The following is a description of a gene set: Human Gene Set: MIR10394_5P studied in species Homo sapiens Genes predicted to be targets of miRBase v22 microRNA hsa-miR-10394-5p in miRDB v6.0 with MirTarget v4 prediction scores > 80 (high confidence targets). from publication Chen Y, Wang X (PMID 31504780), and this is the list of marker genes: NTNG1, DNAJC6, PTCHD1, PNPLA5 (patatin like phospholipase domain containing 5), NFATC2, ADAM7, SPAST, WNK3, ADAM12, PSME4, DIRAS1, SUFU, FHL1, CDS2, TMEM62, N4BP1, USB1, ANKRD17, STAU1, PPARD, GPHN (NCBI Gene Id 57566), KCTD9, TPBG, HACD2, CNTD1, ASB7, GUCA1ANB-GUCA1A, XYLB, TOR2A, ATXN1L, SH3PXD2A, FAM168B, RGMA, TUB, SLC35F6, RBM46, UBE2W, RASGEF1B, USP9X, NPC1L1, SYK, CDCA2, ERLIN1, EBPL, JAM2 (junctional adhesion molecule 2), WSB1 (NCBI Gene Id 26118), ENGASE, ZC2HC1C, SRGAP3, DNAJB1, MTCL2, ORAI2, KIAA0513, ADAR, BICDL1, IPCEF1, CTNND1, CEMIP, CCND2, AP2A2, HCFC1R1, GRIK3, POLDIP2, PPP4R3A, ITPR2, ALDH7A1, PDE3B, SPRY3, AGO1 (NCBI Gene Id 26523), EGLN3, LDAH, DICER1, SETD3, DNAAF9, IGDCC3, CASTOR2, POLR2J3, LACC1, NCKIPSD, UHRF1, PELI2, ST3GAL5, GRM1, CNTFR (NCBI Gene Id 1271), CNOT2, TSPAN13, CACNA1A, QSOX2, FIBIN, RRP7A, PLAGL2, PPIF, FOXI1, MYT1L, EPHA3, USP20, POM121, ICE1, MLXIP, NMNAT2, LHFPL5, ATXN1, ASTN1, FAM120A, TDRKH, KAT7, GSTM4, C1orf21, LBH, TM9SF3, SSH1, ANKS1A, ARF6, SLC24A4, GLI3 (GLI family zinc finger 3), FBXL8, EIF5A, NCS1, ABI2, BCL2L11, ZDHHC6, SNTG2, CHMP7, CUL4A (NCBI Gene Id 8451), PDE2A, GLIS3, KLK6, ST6GAL2, TMEM230, ZNF592, PCBP4, ARHGAP17, CCR4, DOCK3, MAP1B, AMMECR1, RGS16 (regulator of G protein signaling 16), PTPN11, PRRC2B, ACIN1, C1orf226, DNALI1, SMARCE1 (NCBI Gene Id 6605), TTYH2 (NCBI Gene Id 94015), SLC30A4, SBNO1, LSM14A, JCAD, FAM98A, SNX21, GUCA2A, ADNP2, DSE, NATD1, CLTCL1, COPS2, MKNK1, CABYR, EIF5A2, PPP1R3B, FAM217B, SLC4A4, MUC6, RAPGEF1, H2AJ, RAB8B, SLC35A3, TMEM248, MFSD9, NT5C2, GMFB, TXNDC17, PTBP1, SFRP1, AMZ1, TEAD1, RNF19A, ZNF862